The following is a description of a gene set: species: Mus musculus Genes predicted to be targets of miRBase v22 microRNA mmu_miR_1839_3p in miRDB v6.0 with MirTarget v4 prediction scores > 80 (high confidence targets). from publication Chen Y, Wang X (PMID 31504780) Mouse Gene Set: MIR_1839_3P, and this is the list of marker genes: Snap25, Chd6, Kidins220, Txn2, Frmd4b, Mtmr4, Lyz2, Zfp558, Irf1, Pcdhb18, Sytl5, Col5a1, Atp6v1a, Klhl42, Taok1, Yme1l1, Rasl12, Kpna6, Dcc, Zeb2, Nudt5, Rictor, Pkp4, Nlrp4g (NCBI Gene Id 235779), Slc35f3, Cbl, Lyz1, Tmem230, Grpel1, Pimreg, Trp73 (transformation related protein 73), Spink6, Ldhb